The following is a description of a gene set: from publication Belyaev NN, Biró J, Athanasakis D, Fernandez-Reyes D, Potocnik AJ (PMID 22581009) species: Homo sapiens Development of T-cells provides a unique opportunity to study cell-fate determination due to the accessability and the well defined stages of developmental stages. In order to understand the genetic programs underlying fetal and adult T‑cell fate specification we subjected highly purified fetal and adult T-cell progenitor populations to a genome‑wide transcriptional analysis. The aim was to identify molecular elements that govern T-cell fate specification as a whole but ultimately to isolate elements that were specific for a given population in a specific developmental window. Genes down-regulated in comparison of thymic progenitors versus DN3 thymocytes. Human Gene Set: GSE24142_EARLY_THYMIC_PROGENITOR_VS_DN3_THYMOCYTE_DN, and this is the list of marker genes: HMGCS2, TMEM50B (NCBI Gene Id 757), HIVEP3, IL2RA, EDEM1, DHX40, TNFAIP8L1, FHIT, COQ10A, CLK3, ETS2, PKP3, LDHB, LCK, SLC37A2 (NCBI Gene Id 219855), CTLA4 (cytotoxic T-lymphocyte associated protein 4), GPSM2, DUSP10, CYB5A (NCBI Gene Id 1528), SLA2, PHTF1, ANKS3, NCK2, TPST1, PRKCB, FKBP5, ALDH1B1, MLH3, PRNP, ADA, HSD11B1, MED20, ITK, SLAIN1, SIT1, BST1, ABHD8, TCF25, RHOA, FYB1, CD247, PTPRF, RGCC, MCUB, ENDOU, IFNGR1, RAB3IP, GCOM1, TCOF1, ANXA2, CLTB, CTSV, HIBADH, TRIM11, SH2D2A, F2, SLC35D1, PRRT1, AGPAT3, GDPD1, RAG1, TRAF1, PMEPA1, ABLIM1, SAPCD1, CD3D, ARHGAP9, GFI1, PGS1, MBNL3, DGKA, CARD10 (NCBI Gene Id 29775), ITGB4, TSPYL4, IFT25, DGKE, MPP1, MBP, MTRES1, ENTPD5, ATOH8, GALNT10, C1QTNF1, DIPK2A, ANGPTL2, MLX, AKAP12, ENSA, TULP3, LRRC42, EPB41L4A (NCBI Gene Id 64097), ETS1, IL34, SPRY1, SMARCA4, TEC, LEF1, GFRA1, PLA2G12A (phospholipase A2 group XIIA), SPIB, PRKCH, DNMBP, DAPK1, TRIM46, TMEM151B, TOLLIP, EMC3, PLIN3, CD3E (NCBI Gene Id 916), ATP1B1, SCML4, HECTD3, CD28, TNNI3, PDCD1, NGLY1, XRCC6, KLC3, IFT80, ATP8A1, TCF12, AXL, TUBB3, NABP1, SPINT2, SEC24D, ARPP21, DYNLT5, SLC12A4, RPS6KL1, MLLT3, PPT1, PLD4, TP53I13, SOCS1, SH3KBP1, AGFG2, MS4A6A (NCBI Gene Id 64231), TPRKB, RHOH, SLC11A2, EPCAM, TMEM131, SH2D1A, DESI1, NSG2, PTCRA, MIA2, BCL2, FBLN2, HPCAL1, SLAMF6, SPATA6, ANGPTL6, SOCS3, BRDT, DEGS2, GPAM, CDH1, PLD3, MPG, DGUOK (NCBI Gene Id 1716), ID3, LAT, TUBG2, TMC6, TMEM120B, AHI1, ELOVL5, UBE2J1, ITPR2, BCL11B, AAK1, ACAA2, ACTN1, PITHD1, GRAP2, SLC66A3 (NCBI Gene Id 130814), GLCCI1, RALGPS2, THY1, ITM2C, DNLZ, MBTPS1, DEGS1, NRP1, METTL8, C2CD2L, MTF2, AUH, IL7R, FBXL12, CBX4, TMPRSS4, UBL5 (NCBI Gene Id 59286), TMEM242, HSDL2, SLC5A9